The following is a description of a gene set: species: Mus musculus Genes predicted to be targets of miRBase v22 microRNA mmu_miR_495_5p in miRDB v6.0 with MirTarget v4 prediction scores > 80 (high confidence targets). Mouse Gene Set: MIR_495_5P from publication Chen Y, Wang X (PMID 31504780), and this is the list of marker genes: Zfp281, Qng1, Ccar1, Pgr, Cfap43, Dennd5a, 4930519G04Rik, Ptbp2, Tcf7l2, Serpinb9b, Mbip, Fmn2, Daw1, Gtf2a1, Hmga2, Nol4l (nucleolar protein 4-like), Nexmif, Git2, Fam120a, Pcdh10, Ank2, Plaat1, Hnrnpd, G6pc2, Atp8b5, Atp2c1, Fzd4, Kremen1, Itpripl2, Gfer, Sirpa (signal-regulatory protein alpha), Camta1, Zfp36l1, Txndc5, Fam120b, Cpsf6, Cldn34d, Ppip5k2, Ncoa2, Atxn1, Ppp2r5e, Slc4a4, Dipk2a, Paip1, Ppp1r3d, Ggnbp2, Immt (inner membrane protein, mitochondrial), Calcrl